The following is a description of a gene set: Neighborhood of SPTB spectrin, beta, erythrocytic (includes spherocytosis, clinical type I) in the GNF2 expression compendium Human Gene Set: GNF2_SPTB Neighborhood of SPTB studied in species Homo sapiens, and this is the list of marker genes: ANK1, HMBS, H1-0, MINPP1, TRIM10, TAL1, UROD, EPB42 (erythrocyte membrane protein band 4.2), FOXO3, GYPC, NARF, GATA1, CA1, KEL, HBD (hemoglobin subunit delta), SPTA1, GLRX5, EIF1AY, H4C3, HEBP1, SLC12A3, SELENBP1, MAP2K3, CROCCP2 (CROCC pseudogene 2), PRDX2, CTSE, CDC27, SLC22A4, GCLM, SLC4A1, NFE2, AHSP, KLF1, SPTB, TSPAN5 (NCBI Gene Id 10098), CA2, RHAG, UBAC1, RNF123 (ring finger protein 123), ALAD, RHCE, RAD23A, DCAF11, MARCHF8, ERMAP, TMCC2, ALAS2, GYPB, BNIP3L, RANBP10, RHD, XPO7, GYPE, KAT2B, FECH, FBXO7, EIF2AK1, ICAM4, OSBP2, HBQ1, SNCA, TFDP1, MPP1, BSG, GYPA, BLVRB, PPOX (NCBI Gene Id 7440), TSPO2, CLIC2, TRAK2, NUDT4, XK, ACSL6, SLC6A8